Given this list of marker genes CFC1B, CRIPTO3, CFC1, SRC, CDH5, NEO1, BMP4, PYCARD, BMP7, SCUBE3, BMP3, RSPO2, NODAL, CRIPTO, MAGI2, SMURF1, BMP5 (NCBI Gene Id 653), FKBP1A, ELAPOR2, BMP6, SMAD6, INHBA, SMAD7, BMP2, here is a description of the gene set: species: Homo sapiens Binding to a receptor that spans a cell membrane and possesses protein serine/threonine kinase activity. Human Gene Set: GOMF_TRANSMEMBRANE_RECEPTOR_PROTEIN_SERINE_THREONINE_KINASE_BINDING